The following is a description of a gene set: Any process that stops, prevents, or reduces the frequency, rate or extent of neuron projection regeneration, the regrowth of neuronal processes such as axons or dendrites following their loss or damage. Mouse Gene Set: GOBP_NEGATIVE_REGULATION_OF_NEURON_PROJECTION_REGENERATION species: Mus musculus, and this is the list of marker genes: Kremen1, Xylt1, Ptprs, Cers2, Map4k4, Rtca, D130043K22Rik, Epha4, Rgma, Tnr, Lrig2, Rtn4, Diaph1, Rtn4rl1, Pten, Thy1, Diaph2, Rtn4r, Neo1, Inpp5f